The following is a description of a gene set: studied in species Homo sapiens Human Gene Set: GOBP_REGULATION_OF_EMBRYONIC_DEVELOPMENT Any process that modulates the frequency, rate or extent of embryonic development., and this is the list of marker genes: CFL1, RPS6KA6 (ribosomal protein S6 kinase A6), NOTCH1, HESX1, INO80B, NOCT, LHX1, OSR1, TADA2A, DR1, RACGAP1, WNT1, SGF29, LAMA5, TGIF2, LAMA4, UTP25, TDG, CTNNB1, CDK1, PAFAH1B1, LAMA2, NLRP5, EHMT1, YEATS2, WDR5, NR2C2, KAT2A, SFRP2, NFE2L2, AMOT, TLE6, TRIP12, BAG6, WNT2B, RBM19 (NCBI Gene Id 9904), TFPT, RUVBL2, INO80, INSR, DHX36, KAT2B, MCRS1, WNT4, PLCB1, ACTR5, RUVBL1, JAG1, SCX, CCSAP, LAMA1, NODAL, HNF4A, MSX1, POGLUT1, YY1, MBIP (NCBI Gene Id 51562), PHLDA2, FOXA2, TGIF1, SOX17, DLL1, OTX2, ACTL6A, INO80E, NIPBL, LAMA3, KAT14, NFRKB, WNT3A, RAB14, CRB2, TENM4, TADA3, NKX6-3, UCHL5, ZZZ3, B4GALT5, KHDC3L, ACTR8 (NCBI Gene Id 93973), WDPCP, WNT2, ZBED3, INO80C, INO80D, HES1, SEPTIN7, RACK1